The following is a description of a gene set: studied in species Homo sapiens Any process that results in a change in state or activity of a cell (in terms of movement, secretion, enzyme production, gene expression, etc.) as a result of a stress acting at the endoplasmic reticulum. ER stress usually results from the accumulation of unfolded or misfolded proteins in the ER lumen. Human Gene Set: GOBP_RESPONSE_TO_ENDOPLASMIC_RETICULUM_STRESS, and this is the list of marker genes: RASGRF2, YOD1, KCNJ8, CAV1, IKBKG, MAN1B1, PSMC6, MAP3K20, EDEM2 (ER degradation enhancing alpha-mannosidase like protein 2), AFG2B, CXCL8, RACK1, UBE2J2, BCL2L11, SVIP, ERP27 (NCBI Gene Id 121506), PIK3R2, SEL1L, CASP4, TMX1, HYOU1, CCDC47, UBXN10, ASB11, TRIB3, CREB3, USP25, SGTA (small glutamine rich tetratricopeptide repeat co-chaperone alpha), DNAJB12, STT3B, ATP2A2, STC2, COPS5, PMAIP1, PDX1, FBXO6, AQP11, DERL1, JAGN1, ATG10, ATAD3A, SEL1L2, ABCA7, WFS1, ITPR1, ERO1A (NCBI Gene Id 30001), ERLIN1 (ER lipid raft associated 1), ATP2A3, CREB3L1, DDRGK1, RNF121, DDIT3, RNF5, TTC23L, ATXN3L, TMEM129, EIF2AK3, CREB3L2, CLU, NCK2, BAX, CALR3 (calreticulin 3), AKT3, VAPB, ATF6B, UBE2J1, MAP3K5, FBXO2, CDK5RAP3, NCK1, RASGRF1, PPP2CB, FIS1, AUP1, THBS4, RNF103 (ring finger protein 103), BOK, PARK7, CREBZF, PPP1R15B, NPLOC4, MAGEA3, FBXO17, EIF4G1, UBXN4, ALOX15 (arachidonate 15-lipoxygenase), DNAJC3, CEBPB, MIR199A1, TMCO1, PML, RNFT2, AKT1, CREB3L3, BAK1, CCND1, SERP2, MAN1A2, FICD, EIF2B5, HERPUD2, HSPA1A, BCAP31 (NCBI Gene Id 10134), ATF4, UBE4B, PDIA3, PARP8, SERP1, PIGBOS1, SDF2L1, TARDBP, HERPUD1, DAB2IP, RNF145, FAM8A1, RPAP2, ANKS4B (ankyrin repeat and sterile alpha motif domain containing 4B), CANX, CTH (cystathionine gamma-lyase), RCN3, NUPR1, MARCHF6, TMTC4, SCAMP5, BBC3, MAN1C1, RNF7, NR1H2, CALR, PARP16, JKAMP, BCL2, TMEM238L, USP19, UFD1, GORASP2, SELENON, TOR1A, FBXO44, DNAJB9, GSK3B, NCCRP1, PDIA4, RNF183, P4HB, TMBIM6, RNF186, FAF1, TRAF2, SERINC3, RNFT1, BRSK2 (BR serine/threonine kinase 2), SELENOK, USP14, ANKZF1, TBL2, PDIA6, FOXRED2, NIBAN1 (NCBI Gene Id 63911), ATF3, NFE2L1, PARP6, TNFRSF10B, MARCKS, SELENOS, RNF139, TMEM117, GRINA, HM13, UFC1, FCGR2B, RNF175, SEC16A, TRIM25, RNF185, QRICH1, AKT2, TXNDC12, FBXO27, MAN1A1, NR1H3, ERMP1, UBXN8, PIK3R1, FAF2, SRPX, EIF2AK2, TRIM13, STUB1, ERP44, UMOD, HSP90B1, PRKN (parkin RBR E3 ubiquitin protein ligase), ATF6, ERLEC1, APP, DDX3X, LRRK2, XBP1, EDEM1, UBXN1, UBAC2, AMFR, ABL1, NOD1, TMEM258, MBTPS2, EIF2S1, PTPN1, TMTC3, NRBF2, ECPAS, UFL1, CLGN, UBXN6, BFAR, SGF29, DNAJB2, UBE2G2, EDEM3, UBE4A, SESN2, CHAC1, ATXN3, PTPN2 (NCBI Gene Id 5771), FLOT1, TMEM259, APAF1, BAG6, RHBDD1, MIR200C, DNAJC10, NFE2L2, CERT1, CREBRF, HSPA5, RHBDD2, UBQLN1, MANF, BCL2L1 (NCBI Gene Id 598), TP53, TMUB1, MBTPS1, BBS1, ATP2A1, AFF4, VCP, ALOX5, UBXN2A, OS9, NHLRC1, DERL3, TMED2, UBQLN2, LPCAT3, ERN1, EEF2, AGR2, SEC61B, AIFM1, UBA5, USP13, ERP29, SYVN1 (NCBI Gene Id 84447), TMUB2, PPP1R15A, UFM1, ERN2, CFTR, PDIA2, FUT1, TMEM67, BBS10, THBS1, JUN, TMEM33, GET4, DERL2, SIRT1, OPA1, TMBIM4, ERLIN2, BHLHA15